Given this list of marker genes VCL, PECAM1, DSG2, CTNND1, DSG3, ZDHHC7, here is a description of the gene set: studied in species Homo sapiens Human Gene Set: GOBP_REGULATION_OF_PROTEIN_LOCALIZATION_TO_CELL_CELL_JUNCTION Any process that modulates the frequency, rate or extent of protein localization to cell-cell junction.